The following is a description of a gene set: Genes having at least one occurrence of the highly conserved motif M76 CAGGTA in the regions spanning 4 kb centered on their transcription starting sites. This matches the TCF8 transcription factor binding site V$AREB6_01 (v7.4 TRANSFAC). Human Gene Set: CAGGTA_AREB6_01 Comprehensive identification of all functional elements encoded in the human genome is a fundamental need in biomedical research. Here, we present a comparative analysis of the human, mouse, rat and dog genomes to create a systematic catalogue of common regulatory motifs in promoters and 3' untranslated regions (3' UTRs). The promoter analysis yields 174 candidate motifs, including most previously known transcription-factor binding sites and 105 new motifs. The 3'-UTR analysis yields 106 motifs likely to be involved in post-transcriptional regulation. Nearly one-half are associated with microRNAs (miRNAs), leading to the discovery of many new miRNA genes and their likely target genes. Our results suggest that previous estimates of the number of human miRNA genes were low, and that miRNAs regulate at least 20% of human genes. The overall results provide a systematic view of gene regulation in the human, which will be refined as additional mammalian genomes become available. from publication Xie X, Lu J, Kulbokas EJ, Golub TR, Mootha V, Lindblad-Toh K, Lander ES, Kellis M (PMID 15735639) studied in species Homo sapiens, and this is the list of marker genes: SLC25A28, SLITRK4, LRP2BP, ATP1A3, CD37, CSRNP3, NDRG4, LCE5A, MYH7, LINC00649 (long intergenic non-protein coding RNA 649), GABRA1, FGF20, EIF5 (NCBI Gene Id 1983), FAM131A, TGFBI, KCNA1, ADRB2, ANKRD36B (NCBI Gene Id 80265), SLC39A5, STAG2 (NCBI Gene Id 10735), PORCN, PGAP6, AOC2, PRKCZ, SH3BP1, FHIT, GGNBP2, MYB, TLK2, S100A14, EGLN3, RSKR, ADAMTSL1, PTPN2, PACRG, AGER, TBC1D5, NTN5, MBD5, OSBPL11, KCTD5, MBNL1, CAPZA1, PDGFC, PSORS1C2, SYT5, HOXC4, CTF1, CDK6, GCG, HOXC6, STRIP1, ELOC, HOXC10, GAP43, CDKL5, CRTC1, IFT52, DHRS3, CDKN2C, MYOF, PPM1B, DMD, PVALB (NCBI Gene Id 5816), PBX1, MYOZ3, TACR1, MSI1, TBCC, STRN4, PLEKHG6, BDNF, AGPS, ZBTB5, BRINP3, BZW2, UBE4B, CDH24, EFEMP1, NDRG3, RGS22, PLAGL1, STOML2 (NCBI Gene Id 30968), PPP2R2A, PURA, TMTC4, VWA7, TMEM256, CNTNAP4, GPR173, USP2, TMEM184B, PGGHG, CABP4, HYCC1, PHC1, NRK, CORO1A, KRT8, SLC34A3, FBXW11, DCLK1, TECTA, PRLHR (prolactin releasing hormone receptor), PNMA5, SLC38A1, PRRG2, ALDH1A2, GATA2, BRPF1, WNK3, NR1D1, TFAP2A, PNOC, SHISA6, SP8, OVOL1, ANP32A (acidic nuclear phosphoprotein 32 family member A), PLXNB3, MYRF, NKX2-8, FOXA1, MAEA, KCNJ2, RABGAP1L (RAB GTPase activating protein 1 like), PTCH1, UBE2Z, PDHA2, CBY1, EDC4, ANAPC16, ACKR3, PACS1, TRIM52, ENPP6, HNF1A, CCIN, CRLF1, DTNB, NPAS3, SNW1, DISP2, PTCHD1, SH3KBP1, RUSC1-AS1, LAS1L, MAMDC2, ITGB6, NDP, SNX13, GMPR2, FAM117A, LRFN5, CHST11, CHN2, HMGN2, NUMA1 (NCBI Gene Id 4926), NSUN5P1, KIF13A, BCL6, LRRN1, TAFA1, LAMTOR1, IGSF9B, LHX5, SF1, COL2A1, SEMA5A, NRG1, DUSP7, KCNK1, EXOC3L2, MYH14, ADAMTS15, UNC45A, CEP120, LRRC74A, PPIA (NCBI Gene Id 5478), CACNA2D3, PAFAH1B3, CAPN6, S1PR1, TMEM161B, MPC2, LAT, HCN4, ASCL1, CMTM4, LBX1, SECISBP2, DCX, PXYLP1, SLC5A1, SELENOO, PDLIM4, RBM47, LYPD3 (NCBI Gene Id 94931), GABRA6, BTK, PRKN, DICER1, ATP13A4, ZNF827, AXDND1, ZNRF1, MANF, CRTAM, CYP3A4, HIC1, HEPH, RNF43, PTPRF (protein tyrosine phosphatase receptor type F), SENP1, NSMF, KDM6A, CIPC, CHPF, PPTC7, NOL4, WWC1, C6orf136, PTGR3, CAST, RNF19B, DSG3, ASB9, CABP2, PRSS41, GPM6A, DARS2 (NCBI Gene Id 55157), H3C3, PRKACA, IL23A, TNKS2, CDK2AP1, C8orf82, TEX2, JARID2, LGSN, HOXB4 (NCBI Gene Id 3214), SRCIN1, NMNAT1, DPYSL3, IER3, SLC26A9, ITPKB, SULT1E1, RPL24, PYY2, STIM2, MAML3, EGR3, PHF12, SCAMP3, TLX1, ITGB3BP, NELL2, CHRM1, LYNX1, H3C4, SLC37A4, PTHLH, GCC2-AS1, SOX3, TRIAP1, NUP54, NEK10, CSF2, DDX17, GRM2, LIX1L, MOV10, RBFOX2, ASTN1, VSNL1, SIPA1, PKHD1, BMAL1, LRATD2, TMEM191A, ART3, ZC3H18, KLF10, IGF1, CLCN3, DACH2, RRM1, SGK3, KCNS3, AVPI1, ACKR1, MIR137HG, SLC26A7, SOBP, ZSWIM8, CIC, LZIC, EVC2, CXCR4, HOXD8, MSX1, BUB3, NRXN2, POMZP3, MSS51, GSKIP, SLC44A3, TYRO3 (NCBI Gene Id 7301), UBE2D3, H2BC10, DOCK9, GATA1, PLA2G4B, ZNF362, REPS2 (RALBP1 associated Eps domain containing 2), PCDH10, ADAMTS19, CNOT7, GPR22, DBNDD2, CCN5, HNRNPH1, IL22, CCDC102A, SRSF2, ESR2, PDE4D, ARID4A, TCEAL3 (NCBI Gene Id 90845), CSAD, EPS8L1, BCL11B, ULK1, EPHB2, FOXP2, EGF, CSMD3, PHETA1, SPRY2, SEZ6, EED, PRDM13, ITIH6, AGR2, PRDM12, LRMDA, SOST, HAS2 (NCBI Gene Id 3037), BEST3, FXYD2, XIAP, H2BC7, MAP3K5, MED27, ATRAID, PTPRR, CABCOCO1, RARA, TMEM33, PROX1, SMO, ESCO1, WRN, ATP6V0A4, CSRP3, HGF, TEAD3, DNAJC5B, MGAT2 (NCBI Gene Id 4247), SLC5A6, GPC3, CNTN6, DENND2B, CCER1, DIAPH1, CHST9, LYPLA2, KIF7, SOX5, DOLPP1 (dolichyldiphosphatase 1), S100A10, CKMT1B, RB1CC1 (NCBI Gene Id 9821), RUFY4, MAP4K4, SRGAP1, BEST4, GPR85, MTRFR, PMS2P5, KCNE5, SFRP1, NFIX, SOX12, TACC1, MRPS34, NTF4 (neurotrophin 4), FKBP3, E2F8, RAB43 (RAB43, member RAS oncogene family), TXNIP, KCTD6, IL13RA1, AXIN2, NFIB, ABTB3, CBLN1, TRA2A, GPC4, CD40, CCR3, H3C8, ZBTB18, GRHL2, ACSL5, KCNAB1, RAB1A, PIAS1, NEUROD1, RPS6KA3, HOXD4, CABP7, ENHO, CACNB2, ENSG00000291228, NPR3, REEP1, FERD3L, APLN, TGFB2 (NCBI Gene Id 7042), S100A2, CACNA1D (NCBI Gene Id 776), PIK3CG, MIR503HG, IGFBP5, H1-3, CYP3A7, ZNF593, GNG3, NEUROG1, C1orf116, PTK7 (protein tyrosine kinase 7 (inactive)), JADE2, PWWP3B, IGSF10, SMURF2, GPR119, SARNP, CDH6, FLOT1, ZEB2, ALDH3B1, CFAP70, NAT8L, CACNA1G, TSPEAR, TSPAN6, PPP4R3A, GPR21, SLC4A10, RAB8B, ATXN7L1, VAMP8, PTGFRN, LUC7L3, ANKMY2, NKX2-5, LDOC1, CALM2, ESRRG, PXN, HMGN5, HDDC3, MIA, CERCAM (NCBI Gene Id 51148), CER1, PDGFB (NCBI Gene Id 5155), LPAR1 (lysophosphatidic acid receptor 1), CFAP161, PRR15, KCNH5, FSIP2, CHSY1, CYLD, SH2D1A, NRGN, PPP2R2B (protein phosphatase 2 regulatory subunit Bbeta), OXR1, FGF11, RPRD2, RABEPK, FBRS (fibrosin), NMBR, FAM81A, ZDHHC5, GREB1, ETV5, FGF9, GPR152, GNRH1, TRAF3IP2, KHDRBS2, ITGB8, CYRIA (CYFIP related Rac1 interactor A), STK35, TGFB3, MBD6, PTGES3, BSCL2, NAALADL2, KCND3, CCDC120, TMEM38A, PABIR2, LAMTOR3, PRPF38B, ZNF746, HMGA2, FNBP1L, ING2, NTNG2, TRPS1, TBX6, EGR2, POM121L1P, DLG2, EPHA7, MSTN, STAG3L4, TMPRSS2, KCNJ14, XYLT2, NRXN3, NACC1, BMP4, TJP2, ALG10 (NCBI Gene Id 84920), R3HCC1L, RBM15B, LHX6, NFIA, PILRB, SLC9A7, UQCR10, UNC50, PHACTR3 (NCBI Gene Id 85418), PLCB1, TGIF2, TBRG1, MGLL, NFE2, PGRMC1, LINC01101, BCL9L, BMP7, FAM72A (NCBI Gene Id 729533), FOXP1, FOXN3, GPRC5C, ZER1, TNFRSF19, LOXL4, ST6GALNAC3, SKIDA1, RNASE11, SIX4, ADAMTS4, NEDD4L, FN1, ICMT, CLDN17, RAPGEFL1, STX5, DCTN1, SH3D21, ID4, EPB42, MIA2, USP25, CD72, KIF1C, SLC30A3, CACNB1, PDGFA, ZDHHC8, OVOL2, MLLT10, OSBPL6, ZIC4, ORAI3, CCDC14, CLCN5, LRRTM3, INCA1, ARHGAP44, OTOP3, HERC4, SEMA7A, ANTKMT, ACTA1, PITX2, RYR2, PNPO, FDPS, UCHL1, ICA1L, LZTS2, FBXL19-AS1, BBX, TBX19, PDE4B, NT5DC3, HEBP1, CELF4, RABL6, ERRFI1, SLC26A1, PPARGC1B, LMX1A, ABLIM3, RLIM, TUG1, SEL1L3, FKRP, CYP26B1, ERG28, VPS37A, MTMR10, ZNF395, LRRFIP2, RPL36AL, RPS6KL1, PPY2P, SP7, FOXB1, TBC1D14, BMP6, CUTA, VTCN1, ORMDL2, DBI, ITPR3, ESRP2, MDFI, TRPM7, BCL11A, NEDD8, ZEB1, DHH, UBA1, EIF4G1, EMX2, HTR1F, EGFLAM, LRIT3, KLF14, WDR6, ZIC1, SPDEF, UBXN10, MLLT6, FAM193B, USP51, LAMA3, FOXP3, ST7L, FGF13, TET1, PAK6, CAMK2A, GRID2, PTK2B, PREX2, IRS1, GDPD2, PTMS, CREB5, DNAJB5, HDAC4, LEAP2, ARAP2, CAPN1, CLSTN3, SLC18A1, GGA2, PTP4A1, IL1R2, PURG, H1-2, PRKACB, ZFHX4, ZNF366, HSALR1, AICDA, IL27, SLAIN1, NR3C2, NPHP4, SHISA7, FAM193A, IL17F, REPIN1, NECTIN4, FOXD3, HOXA13, SND1-IT1, ELL, CCDC7, PLA2G2F, H2AC7, OFCC1, ENOX1, NOSIP (nitric oxide synthase interacting protein), HIVEP1, UCKL1, SAP130, SRPK2, SIRPA, CHL1, CASK, SLC44A1, KLF5, SEMA3F, STC1, ARAP1, FAM106A, TTC39B, MAP2K7, SLC3A2, ATL3 (atlastin GTPase 3), PDGFRA, CDR1, CYB5R3, ZNF503 (zinc finger protein 503), EVX1, FRY, ALDH4A1, PTN, NDUFS2, LMO3, HFM1, NOTCH1, SMARCA1, SOCS2, LMTK2, LSR, AHCTF1, CCDC112, CSF3 (colony stimulating factor 3), BTG4, AGBL5, ARL4C, MSRB3, CD74, PPP4R1, KCNJ15, HIVEP2, H2BC3, RAB2B, IL1RN, NBEA, CADM2, JUP, USO1, PSD, TOMM20, DIO2, PHF21B, LINC01597, DUSP13B (NCBI Gene Id 51207), AVPR2, UMOD, CHST1, LAMB3, SLC17A3, LDB2, CDH16 (cadherin 16), NCAM1, FAM83H, HOXA3, KRT2, DNAJC22, ELAVL4, LAMP5, GNL3LP1, HOATZ (NCBI Gene Id 399949), SLC8A3, BMI1, MMP14, WDPCP, ALS2, MYO1E (myosin IE), NTPCR, SEPTIN4, EPB41L1, KCNT2, TRPV6, IL2, ERBIN, TCF12, FOXG1, HPSE2, JAG1, RAB2A